The following is a description of a gene set: Human Gene Set: GOBP_PROSTATE_GLAND_MORPHOGENESIS The process in which the anatomical structures of a prostate gland are generated and organized. species: Homo sapiens, and this is the list of marker genes: SHH, CYP7B1, FEM1B, NOG, SFRP1, STAT5A, HOXD13, HOXB13, MMP2, IGF1, SULF1, NOTCH1, WNT5A, SOX9, HOXA13, RARG (retinoic acid receptor gamma), TP63, FGFR2, TNC, CRIP1, BMP7, AR, ESR1, FOXA1, FRS2, ID4, FGF10, SERPINB5, NKX3-1, BMP4